Given this list of marker genes Baz2a, Maf1, Macroh2a1, Macroh2a2, Flna, Nop53, Dedd, Smarca5, Crebbp, Actr6, here is a description of the gene set: Any process that stops, prevents, or reduces the frequency, rate or extent of transcription mediated by RNA polymerase I. species: Mus musculus Mouse Gene Set: GOBP_NEGATIVE_REGULATION_OF_TRANSCRIPTION_BY_RNA_POLYMERASE_I